Given this list of marker genes IRX5, DOLK, LMOD2, PLXND1, WAS, FLNC, LAMA4, CITED2, CALM1, SNTA1 (NCBI Gene Id 6640), DUX4L1, SLC1A3, KCNJ11, GNAI2, MT-TL1, ATP6V1E1, PPP1CB, ENPP1, RHAG, EP300, PEX19, TNNI3K, KRAS, DNAJC30, CALM3, CRYAB, SELENON, CDON (cell adhesion associated, oncogene regulated), HLA-DPB1, GSN, DISP1, EYA4, C1QBP, OBSCN, HLA-DPA1, FKBP6, BAG3 (NCBI Gene Id 9531), MGME1, CDH23, CPT2, SLC25A11, NF1, LAMB3, KCNJ18, WIPF1, CLCF1, GPC4, MT-TH, LTBP2, KCNH2 (potassium voltage-gated channel subfamily H member 2, NCBI Gene Id 4027), ABCG5, GTF2I, FKTN, GATA5, GNA11, CSF2RB, BMP4, GCGR, STX16, UCP2, LAMC2, HNF4A, MT-ND4L, RPL3L, PRNP (prion protein (Kanno blood group)), TET2, ACAD9, FNIP1, ACY1, GNAQ, KCNJ8, HEPHL1, MAX (MYC associated factor X), KYNU, NODAL, CUBN, MADD, MYOZ2, PEX16, GALC, RIGI, PEX7, MT-ND5, AGK, FXN, SCN5A, MT-TW, PPP1R13L, TP53, GBE1, TPM2, DNAJC19, KCNA5, MT-CO2, SOX10, RAF1, KCNE2, PEX2, KCNK3, TERT, PSAP, TBX1, NDUFS2, TMEM127, JAG2, SVIL, HDAC4, FMO3, KCNE5, AIP, LHX3 (NCBI Gene Id 8022), TGIF1, PTPN11, TMPO, RAB3GAP2, VPS33A, PCCB, ZNRF3, SDHAF1, NRAS, RYR1, PYGM, ATRX, COX7B, DMPK, LZTR1, TAFAZZIN, SLC2A10, NDUFA8, FOXH1, DBH, DSG2, PEX5, BAG5, PSMD12, PSMB8, CDKN1A, AKT1, NEU1, SLC40A1, SCN4A, ADAMTS19, PRKAG2, LIPT1, NDUFB11, DEPDC5, CDKN2B, SFTPC, CAPNS1, LRP1, SDHB, DLST, MT-CO3, FRG1, ELN, SCNN1B, SRY, ASXL1, MT-TQ, VHL, SIX3, VEZF1 (vascular endothelial zinc finger 1), CAV3, DPAGT1, CPT1A, FGF8, FHOD3, IPO8, LDLRAP1, CRLS1, KCNE3, MRPS14, POLG2, LIMK1, MT-ND1, GET3, PRORP, KCNE1, CASQ2, HBB, GAA, RHCE, GATAD1, SLC6A8, IQSEC2 (IQ motif and Sec7 domain ArfGEF 2), TSC1, ATPAF2, KIF20A, CASR, MYPN, ACADVL, CALM2, HFE, RET, HADH, PRTN3, SCO2, LMNA, DCAF17, SRSF2, SOS2, APRT, TTN, KCNJ3, NOS1AP, PPCS, ACTB, HRAS, NDUFA2, CDKN2C, ABCG8, PRKG2 (NCBI Gene Id 5593), STX1A, NDUFAF1, PCSK9, MFAP5, MYL2, PEX14, ECE1, RNU12, ACADM, PAX8, PEX26, SLC25A20 (solute carrier family 25 member 20), GNAS, EMD, ASL, SAA1, PEX3, MMACHC, SCUBE3, FOXC2, PEX6, TPM3, DST, GPD1L (glycerol-3-phosphate dehydrogenase 1 like), MT-TS2, ATP1A3, TMEM270, FGFR1, HLA-B, ABCA3, ALDOA, MYZAP, NAA10, COQ9, PITX2, CIZ1, PGM1, MYL3, CACNA1S, SDHA, PLEC, FBN1, TGFBR2, GABRA3, SCN3B, RFC2, CACNA2D1, FH, HCN4, GNB2, SLMAP, PEX1, SYNE2, PTPN22, SCN2B, DEAF1, MYRF, DMD, ATP1A2 (ATPase Na+/K+ transporting subunit alpha 2), SPRED1, SCN4B, ATP5F1D, KLHL24, DSC3, MECP2, TSC2, MT-ATP8, TDP2, PTCH1, RBM20, ALPK3, FBP1, LEMD2, XK, DEF6, LDLR, COL4A1, BMP2, TOR1AIP1, PNPLA2, SOS1, SLC19A2, TBX5, PIK3CA, RRAS2, GJA5, KCNQ1, RASA2, DSC2, ATP5MK, MMP2, LARS2, CACNB2, CDC73, NPPA, GATA4, GRIN1, ANKRD1, TNNC1, TSPYL1, MRPL12, TBX3, COQ4, MYLK2, ABCC8, TNXB, TLL1, TECRL, CTNNA3, HLA-DRB1, SCO1, TG, CTNNB1, FLAD1, SPRED2, MT-TV, GPX4, MGAT2, SFTPB, SCN1B, POMT2, POLG, GPR101, CLCN1, MT-CYB, TAB2, CACNA1D, MT-ND2, YY1, HMBS, STAG2, ATP5F1E, GTF2IRD2, P4HA2, NKX2-5, LAMP2, JUP, NKX2-6, GATA6, GLUL, AKAP9, PEX11B, IFT56, MTFMT, HJV, FHL1, CBL, GMPPB, ATP5F1A, PSEN2, RHD, SGO1, TOR1A, TSHR, CTLA4, CACNA1A, TRDN, CSF2RA, TRPM4, JPH2, ADAMTS10, PEX13, SCN10A, EFEMP2, IFNG, GTPBP3, ZIC2, PLCH1, GLYCTK, PSEN1, GYG1, TSHB, NCF1, GNB5 (NCBI Gene Id 82962), CREBBP, PIGA, UQCRFS1, DYSF, SDHAF2, DPP6, SMC1A, THRB (NCBI Gene Id 7068), MT-TC, MT-CO1 (mitochondrially encoded cytochrome c oxidase I), MYL4, HSPG2 (heparan sulfate proteoglycan 2), CCND1, TTPA, TNNT2, METTL27, DUOX2, STIL, ABCC9, LHX4, SMCHD1, ERCC6, MDH2, KCTD1, NFIX, CPOX, SLC4A3, CLCNKB, DES, TBX20, GFM2, SGCD, LAMA3, KCNJ5 (potassium inwardly rectifying channel subfamily J member 5), BPTF, BRF1, CSRP3, DUOXA2, LPIN1, ABCA12, TCAP (titin-cap), PEX10, TMEM70, GLI2, COL6A1, PHOX2B, VPS37D, MPV17, LRP12, MYH6, FLII, LRP6, CAP2, FBXL4, TXNRD2 (thioredoxin reductase 2), ISCU, SEMA3A, PPOX, GPC3, CRELD1, SDHC, EXOSC5, HESX1, BMP6, PCCA, TWNK, KCND3, CDC45, MRAS, BTNL2, ACTC1, MEN1, KIF1B, ANK2, SALL4, RANGRF, ABCC6, DLL1, GAS1, HMGCL, BRAF, DUX4, ZFHX3, ARSB, MYH7, PKP2, SLC25A4, CDH2, IKZF1, SMAD3, DNMT3B, DSP, CDKN2A, ACTA1, DOHH, MMP14, EIF4H, IVD, LDB3, HCCS, PIGU, IYD, PLN, TNNI3, SYNE1, MT-ND4, AGXT, EPAS1, RRM2B, TOP3A, PROP1, TMEM126B, GBA1, SDHD, CLIP2, MYO1H, DNMT3A, PRKAR1A, TPM1, ZNF699, BANF1, MYBPC3, RNASEH1, GDAP1, RMRP, TGFB2, CACNA1C, CNBP, GJA1, TGFBR1, VCL, PPA2, TAF1A, TBL2, TMEM43, CAVIN1, MEFV, HTRA2, PRDX1, GTF2IRD1, DHCR7, TPO, HAND2, RAI1, POU1F1, TTR, MT-ND3, RIT1, ELP1, ACTN2, NUP155, SHH, SMAD2, SLC12A3, CDKN1B, CORIN, TANGO2, SCNN1A, FHL2, MT-TF (NCBI Gene Id 4558), ALG10B, SLC5A5, PEX12, HNF1A (NCBI Gene Id 6927), CLIC2, BUD23, HADHB, NAXD, ECHS1, ERCC8 (NCBI Gene Id 2075), NEXN, DTNA, KIT, RYR2, KCNJ2, MT-ND6, BRAT1, SPECC1L, ADAMTS17, MT-ATP6, AMN, USP18, CRIPTO, LAMA2, RRAS, GLA, PHYH, SCNN1G, SCN9A (sodium voltage-gated channel alpha subunit 9), BAZ1B, TGFB3, MT-TK, WIPI2 (NCBI Gene Id 51623), BVES, PRDM16, HADHA, MTO1, IDS, APOB, CRLF1, here is a description of the gene set: An anomaly of the electrical conduction physiology of the heart. Abnormality of cardiovascular system electrophysiology Human Gene Set: HP_ABNORMALITY_OF_CARDIOVASCULAR_SYSTEM_ELECTROPHYSIOLOGY species: Homo sapiens